Given this list of marker genes TNS1, PLG, ZBTB37, ARHGAP21, TAF3, BPIFA1, CCNY, TAS1R3, CYP11B1, CNRIP1, MGLL, CEP83-DT, ZNF385B, B2M, PPP1R7, C1orf210, UNC13A, SLC22A16, GALNTL5, GCA, RGL1, TMT1B (thiol methyltransferase 1B), PPP1R42, SERPIND1, PDZRN4 (PDZ domain containing ring finger 4), KHDRBS2, FAM221A, GK5, KNOP1, TOMM20L, CER1, KCNK12, RNF150, KRTAP17-1 (NCBI Gene Id 83902), SPMAP2L, PDYN, CLDN9, LCLAT1, TPGS2, OR11H4, FGF21, LRIT1, ZNF597, TRPC6, PSAP, PAH, NLRP4, TTC21A, RNF133, ASXL2, PCMTD2, PRDX1, PXT1, MRPL9, MARVELD2, VGF, IL9, CYP24A1, SSBP1, RIPK4, ADNP, UBD, GHRH, PNLIPRP2, LATS2, LRFN2 (leucine rich repeat and fibronectin type III domain containing 2), PDE11A, CASD1, OVOL2, PRSS56, HRH4, TEKT5, KRT12, CRYGS, CXorf49B (chromosome X open reading frame 49B), CPVL, LETMD1, ACBD5, MRE11 (NCBI Gene Id 4361), AGGF1, BAZ2B, KRT26, NKPD1, H2BC13, ZFP62, GPR101, FGF2, IL1RAPL2, TVP23B, SLC25A36, SPCS1, KCNH1, CADPS, FAM210B, RAPGEF4, RSPH6A, COMMD10, SMIM7, LRRC49, CYP2F1, HCRTR2, CDHR3, TOMM22, PLA2G4D, SSTR5, REG4, ZIC4, TMED6, RHOF, CPEB4, TSSK6, LZTFL1, ERICH2, PIGR, ANKRD34B, PAX5, STEAP2, LRP2BP, IL27RA, GTF2A1L, ESD, DMRT1, SPATA19, MLC1, BECN1, MBTPS2, TSPO2, DSE, LIX1, POM121L12, TMEM52, ANO9, APEX1, ATF2, PLA2G2F, UBE2D3, UNC45A, ATP6V1G1, CLDN19, PLPP5, EPPIN, ACTL9, SSR1, UGT2B10, PPY, CAPN11, CCDC191, ANKRD52, ADM2, OR4E2, ADAMDEC1, RAB6B, LGALS2, CNGA1, NPLOC4, VN1R5, ACBD7, ATP6V0D2, CBLN4, MMP12, KCNC1, PAPOLB, ELOVL3, NRGN, SPTLC1, PJA1, STPG3, FMO3, DOCK11, PVT1, ANKDD1B, GSTM1 (glutathione S-transferase mu 1), SLC5A9, PPIL6, SRRD, CWF19L2, CTRB2, SMR3A, NGB, CADM3, RTN4, PLEKHG6, SPINK1, TBX5, LAMC2, BLOC1S6, ARHGEF2, CDCA7L, APOC3, CFAP97D1, SLC25A48, ZNF644, BMP10, KLF17, PROB1, NODAL, C18orf54, PIGH, ZNF532, here is a description of the gene set: from publication Feng J, Wang H, Shin DM, Masiuk M, Qi CF, Morse HC 3rd (PMID 21178004) species: Homo sapiens Conditional IRF8 KO mice (mice with a conditional allele of Irf8 crossed with CD19-Cre mice) showed increased numbers of both Gene expression data spleen marginal zone (MZ) and Gene expression data spleen follicular (FO) B cells compared to control mice. To evaluate gene expression patterns that distinguished FO or MZ B cells derived from conditional KO and control mice, we used Affymetrix GeneChip® Mouse gene 1.0 ST Array. Human Gene Set: GSE24972_WT_VS_IRF8_KO_MARGINAL_ZONE_SPLEEN_BCELL_DN Genes down-regulated in spleen marginal zone B lymphocytes: wildtype versus IRF8 knockout.